The following is a description of a gene set: Genes predicted to be targets of miRBase v22 microRNA hsa-miR-6806-3p in miRDB v6.0 with MirTarget v4 prediction scores > 80 (high confidence targets). species: Homo sapiens from publication Chen Y, Wang X (PMID 31504780) Human Gene Set: MIR6806_3P, and this is the list of marker genes: KRTAP9-3, WDFY2, BLVRB, TESMIN, ELP3, MAGEA10, DYNLT5, FBXL20, PDE1C, SATB1, ELOVL6 (NCBI Gene Id 79071), COMMD3-BMI1, DDI2, SPOCK2, EBF3, CHMP3, PIGN (NCBI Gene Id 23556), ATAD1, TRMT10B, SLC8A3, IGF2BP3, CACNA1E, NRP1, CFAP210, RNF144A, NCMAP, CREB5, GRM6, PHIP, HS3ST2, SULT1C3, DNM1L, MLEC, CPM, POLG, HCFC2, MAP7D2 (NCBI Gene Id 84884), ATOSA, HMG20A, CYP21A2, GC, CLMN, GZF1, PPARGC1A, GABRA4, CA13, KCNC2, C3orf70, TXNDC8, MBNL2, RERE, RNF114, PAX5, DUOXA1, MED14, RBM19 (NCBI Gene Id 9904), RGS7BP, G6PC2, SSX2IP (SSX family member 2 interacting protein), SHISAL1 (NCBI Gene Id 85352), CAMKK2, EPAS1, WDR20, NANOS1, NEK7 (NIMA related kinase 7), BMI1, ZNF282, CD99, MTMR2, COX15, OXR1 (oxidation resistance 1), SRGAP1, UBFD1 (ubiquitin family domain containing 1), PHTF2, MDH2, TEF, MZF1, GPM6B, PRKD3, VSIG10, ZDHHC17, CERS6, KRTAP9-9, CUL3, WBP2, ESR2, AMOT, PPP1R3A, CNOT2, RAB6A, BEND4, SULT1C2, PTPRO, C4orf17, GUCY1B1, CPSF6, CRYZ, HNRNPR, SPRR2F, MKI67, RNF103-CHMP3, SIT1, PRDM6, CDH11, CLRN1, ADRA1A, SPTLC1, HMGXB3